The following is a description of a gene set: studied in species Homo sapiens Human Gene Set: GOMF_PHOSPHATIDYLINOSITOL_PHOSPHATE_4_PHOSPHATASE_ACTIVITY Catalysis of the removal of the 4-phosphate group of a phosphatidylinositol phosphate., and this is the list of marker genes: INPP4B, SACM1L, SYNJ1, FIG4, INPP4A, INPP5F, OCRL (NCBI Gene Id 4952), PIP4P2, SYNJ2, PIP4P1